Given this list of marker genes IL2RA, ZNF335, SH2D2A, IRF1, IMPDH2, HES1, GAL, OCSTAMP, MPL, IGF2, IL4I1, PTPRC (NCBI Gene Id 5788), IL13, MAPK1, GLMN, HLA-A, LRRC32, IL6ST, TYROBP, CD1D, TP53, MYC, TRAF6, SOS2, NPR3, FADD, RIPOR2 (RHO family interacting cell polarization regulator 2), MARCHF7, VSIG4, TNFRSF14, TMEM131L, SDC4, LIPA, CADM1, GPR183, GBA1, JAK2, NCKAP1L (NCBI Gene Id 3071), TNFAIP3, TNFSF14, BCL2, IDO1, CD3E, ZAP70, MEF2C, CD40LG, RIPK2, MZB1, BST2, CD19, LMO1, MAPK3, CSF1, LGALS9 (NCBI Gene Id 90793), NFKBIZ, ELF4, CLC, TWSG1, GSTP1, RIPK3, BMI1, SCGB1A1, CORO1A, IL9, CD151, IGFBP2, MAD1L1 (NCBI Gene Id 8379), CRTAM, CX3CL1, IL5RA, CD38, VTCN1, PLA2G2F, WNT4, NMBR, PRKCQ, SPN, TREM2, BAX, F2RL1, EBI3, CR1, IKZF3, CD46, CD22, AHR, IL12RB1, VCAM1, SLC39A10, FGF10, BID, DLG5, SOS1 (SOS Ras/Rac guanine nucleotide exchange factor 1), CSF2, BTN3A1, CLEC4G, FOXJ1, IL12A, LGALS9C, PLA2G5, SCRIB, BCL2L1, PRKAR1A, IL15, CBLB, PTPN22, BTK, HHEX, LILRB4, HMGB1, BTLA, INPP5D, DHPS, RAC2, EFNB1, ENPP3, WNT3A, PLA2G2A, TLR4, NDP (NCBI Gene Id 4693), IL1A, CCL5, LILRB2, SHB, FKBP1B, FOSL2, HELLS, MAPK8IP1, TNFRSF9, NR5A2, TNFSF8, MS4A1, PAWR (NCBI Gene Id 5074), IL2, CNN2, DOCK8, BTNL2, KITLG, STAT6, SYK, CSF2RA, SFTPD, IL12B, ARMC5, PDCD1LG2, TIRAP, IHH, CD28 (NCBI Gene Id 940), FCGR2B, DOCK2, TNFSF11, TCIRG1, VSIR, ARG1, PYCARD, DLG1, CSF1R, STAT5A, MSN, HLA-DPB1, BAP1, PPP3CA, RC3H2, SHH, ERBB2, PTPN6, TICAM1, IGF1, DNAJA3, NCK2, PSMB10, TNFRSF13B, IL6, CLU, SLAMF1, ATAD5, TNFSF13, LGALS9B, CCL8, TGFBR2, KIT, VAV3, IMPDH1, TACR1, CD320, TCF3, HLA-G, TNFSF4 (TNF superfamily member 4), PELI1, HLA-DPA1, CD80, P2RX7, CD86, ANXA1, RAG2, NDFIP1, HLA-DRB1, PRNP, LILRB1 (leukocyte immunoglobulin like receptor B1), TNFRSF1B, CARD11, HPRT1, ZBTB7B, GPAM, IL10, ICOSLG, CDKN1A, FLT3, FCGR3A, FCRL3, IL23A, FYN, TAC1, MALT1, FLT3LG, EPHB2, NFATC2, MIR30B, SELENOK, ZNHIT1, PCYT1A, HLA-E, CCR2, IL1B, AZI2, IL27, NCK1, RC3H1, TNFRSF21, EPO, IFNB1, CD79A, PRDX2, AIF1, MIR181C, TNFSF18, IL18, HHLA2, CD24, PTK2, TBK1, CCDC88B, IL20RB, CD74, GREM1, CD70, GNRH1, RASSF5, NF1, IGHE, CCND3, SLC7A1, CTLA4, TGFB1, ATM, RASGRP1 (RAS guanyl releasing protein 1, NCBI Gene Id 10125), BCL6, IL21 (NCBI Gene Id 59067), BMP4, CTNNB1, IRS2, SOX11, GPNMB, PTH, LST1, SASH3, TYK2, CD180, ALKBH5, PURA, MIR181B1, PPP3CB, ARG2, PNP, ZP4, RPL13A, IL7 (interleukin 7), ZP3, TNFRSF4, NCSTN, CD274, TNFSF9, MYD88, CD4, CHRNB2, CSF2RB, IL4, PIK3CG, TLR9, MIR21, PKN1, ABL1, MIR185, CD300A, PRKCD, JUNB, CD81, BST1, CLECL1P, PHF7, PTPN11, ADA, HSPD1, PLA2G2D, PLCL2, LYN, CRP, ACE, LGALS3 (galectin 3), CD276, CR2, MNDA, SPTA1, CEBPB, RPS3, STAT5B, SLC4A2, CDKN2A, XCL1, CLCF1, PRLR, EMP2, LEF1, CD6, CD55, IL23R, TSPAN32, CD209, NMB, HAVCR2 (hepatitis A virus cellular receptor 2), RASAL3, SLC11A1, MIF, IL33, GAPT, CTPS1, LEP, ITCH, FOXP3, LAPTM5, TFRC, IL5, CD40 (NCBI Gene Id 958), SH3RF1, CD37, BTN2A2, AGER, HLA-DMB, TNFRSF13C, TNFSF13B, CCL19, IL7R, IL34, CASP3, TMIGD2, LMBR1L, here is a description of the gene set: Human Gene Set: GOBP_LEUKOCYTE_PROLIFERATION studied in species Homo sapiens The expansion of a leukocyte population by cell division.